Given this list of marker genes CNPY2-AS1, RNF13, CAPN15, FANCD2, ADHFE1, PDE6B, LINC01690, PARN, CCSAP, ENSG00000246308, BAIAP3, UTP15, DNAJC25-GNG10, JAKMIP2, ATP8B3, CIR1, OXSR1 (NCBI Gene Id 9943), EFNA3, TSPAN12, NDUFA11 (NADH:ubiquinone oxidoreductase subunit A11), CYP2J2, GTF2H4, MTND4P34, PARP1, MTG1, PEMT, DYRK1B, PLK3, IL6, ACADSB (acyl-CoA dehydrogenase short/branched chain), PFDN1, TMEM186 (NCBI Gene Id 25880), ABCG4 (ATP binding cassette subfamily G member 4), DLGAP5, SPECC1, ZNF160, ENDOG, ASNS, SUB1 (SUB1 regulator of transcription), STX18, DNAJC3-DT, APOO (apolipoprotein O), RAET1K, TRMO, GTPBP3, MIR367, ATP5MK, TRMT5, HTR5A, PTPRF, DYNLT2B, C9, AGPAT4, TREX1 (NCBI Gene Id 82474), HES4, ELOVL1, ZNF229, ZNF668, SOAT1, NT5DC3, ABCA7, CCDC159, ALKBH6, MTMR4, BAZ2B, SLC12A2-DT, ZNF292, CALM1, POLR3C, ATXN7, COPS7A, CXorf58, CDH23, RAB11FIP2, ZSCAN31 (NCBI Gene Id 91921), CIBAR1-DT, PTGES3, ZNF213-AS1, CLDN6, PLA2G4E-AS1, GPANK1, CNN3, SCRN3, MAP4K1-AS1, TBPL1 (TATA-box binding protein like 1), SNORD21, ARHGAP33, CFAP57, ZMYM4, SCGN, CCT6B, ENSG00000282849, SMG5, GPR89B, HECW2, MC1R, KCNT1, LINC01551, SLCO4A1-AS2, ATP5MC2, PDK4-AS1, CCDC192, PRR3, MYO3B-AS1, RNF166, WDR62, RARS1, MCTS1 (NCBI Gene Id 28985), NUP93-DT, ENO3, VPS13C, KIAA1217, DGKZ, CFDP1, LINC01778, BCL2L12, PHC3, RNF115 (NCBI Gene Id 27246), OGT, MEGF10, LMO4, TDRD7, FAM200A, NR4A1, LDLR, CREB3L2, ZNF500 (NCBI Gene Id 26048), CCDC8, RNF103-CHMP3, RNU4ATAC16P, CHMP6, SMARCC2, TNRC6C, LINC02614, ORAI2, AGPAT5, LINC01089, PPHLN1, MEPCE, CFL2, ZNF543, CD72, SCG3, LYRM1, DCTD, HNRNPD, KRBA1, YAP1, IFT140, ARAF, RNF103, PPP1R3B, ITGB3BP, NUP43, MMAB, CZIB-DT, RPA3, NHLRC3, MGST1, MIR760, NFKBIB, CDKN2A, H2AC25, B4GALT3, DLK2 (NCBI Gene Id 65989), CCDC169-SOHLH2, HEXA, RCAN1, TUBA1C, CEP131, FKBP14-AS1, ARID1A, RNF10, CAB39L, SDR39U1, CORO1A, MCCC1, ASCC1, VPS72, PSMA5, AOPEP, ANAPC11, ZNF429, REEP2, CAPN7, ALKBH3-AS1 (ALKBH3 antisense RNA 1), POLE3, CSNK2B, SLC12A2, OTULINL, LDB1, ODAD1, CLPB, FERMT2, C1QL3, OSBPL8, PPP2R5C, PHLPP2, RHOF, MAP2K5, POLA2, BAX, CAPS2, PIGQ, ATP5PD, GBA2, RPL15, RPS26, ZKSCAN2, RAB5B, RNASE11, RNU6-92P, TENT5C-DT, ARV1, KAZALD1, LETM2, ZFP64, DNAJC3, EBNA1BP2, PDGFRL, TM9SF4, KANK3, IKZF5, ZNF892, CASC2, ALYREF (Aly/REF export factor), SLC46A3, SEMA4B, SPNS2, CDR2, WDR59, LSMEM1, KLHL20, ITFG2, MAST4-AS1, TASOR2, BFSP1, SV2C, HIP1R, RWDD1, KIF22, RBPJ, MYLK-AS1, PCGF6, PSMD3, MAML1, RABEP2 (rabaptin, RAB GTPase binding effector protein 2), VARS2 (valyl-tRNA synthetase 2, mitochondrial), KCNK1, SOS1, ATP5MC3, CDR2-DT, CEBPB-AS1 (NCBI Gene Id 440766), RIF1, PDE8A, PEX13, RAB11A, LRRC49, KCTD7, BCAR3, PITPNM2, ACIN1, SCAF4, RNF139, LTBP3, CLIC1, THAP1, HOMER2, PROSER1, ZNF486, ENSG00000272008, ZEB1, SLC38A6, SREBF1, ZNF737, ZFHX2, CIDECP1, LMBR1L, PMEL, SNAP47, GLI2, SEC24B, OSBPL3, OXNAD1, SULT2B1, FOXN1, SPOP, PMVK, PYCR1-AS1, PYGM, NUP54, CCDC169, DSN1, CORO1A-AS1, CHKB-CPT1B, AP1G1, FBXW9, CCDC167, MCFD2, EDF1, CYP2S1, SLC25A15, ENC1, ENSG00000267698, LRRC37A5P, DCLRE1B, DPH3, LINC01607 (long intergenic non-protein coding RNA 1607), REEP6, HIF1A (NCBI Gene Id 3091), ERI2, DHRS13 (dehydrogenase/reductase 13), IGFL4, SLC36A1, ANAPC2, TCHP, ST6GALNAC6, C6orf118, MTND3P13, QNG1, H6PD, BRINP2, LIN54, OSR2, REPS1, UBE2O, PEAK1, ADCK2, RNU11, TBC1D16, TNC, GBA1, NTN3, SEPTIN9, MAP4K1 (mitogen-activated protein kinase kinase kinase kinase 1), C10orf95-AS1, EEF1AKMT3, ACTMAP, RASA4CP (NCBI Gene Id 402490), LPCAT4, DCDC2, ADAMTS13, CEP55, H2AZ1-DT, FBXL19-AS1, FLNA, RLF, ANKRA2, BCAP29, P4HA3-AS1, RNU7-179P, GPR137B, ATXN1-AS1, RIC8A, GDI2, SPAG1, ZNF655, APBB3, FYTTD1, LHFPL4, PMM2, GSAP, PCSK4, EBP, SNORA10, SLCO4A1, VMAC, SLC16A6, RALGDS, CEP89, DCUN1D3, ZFYVE16, ZFP1 (ZFP1 zinc finger protein), ZKSCAN8, FAM133GP, DNAJB9, UGGT2, NDUFA5, TARS2, NABP1, KIF20B, ZNF672, BAP1, CGA, CCDC57, ZNF438, METTL15, FAM199X, MTERF4, KMT2D, HTR3A, FOXK2, TNFSF13, UACA, GDI1, PRKCG, WDR55, DENND4A, RNF139-DT, STX18-AS1, PAK4, RFC1, SQSTM1, ITPRIP, RNU1-6P (RNA, U1 small nuclear 6, pseudogene), SEC61G, ITSN1, TJAP1, SNHG7, MAP3K12, GRK6, ISG15, SEC61A1, CASTOR3P, SLC35A4, MAD2L2, DSG1-AS1, SH2B3, MARCHF6-DT, GOSR2-DT, ZCCHC7, TARBP2, MACF1, RASD2, ACTN4, TMEM97P1, TAF1, CNN3-DT, GABPB2 (NCBI Gene Id 126626), DHRS4L1, PHF7, GFI1, JMJD4, RMI2, NTAN1, GNL1, SNRPA, ZNF689, EFL1P1 (NCBI Gene Id 727963), DNAJB12, ITPR1, GNG12-AS1, TMPRSS2, PHB1, ARHGAP24, NCEH1, TRIM44, LIMA1, CDC42SE1, PILRA, DDX12P, C4orf50 (chromosome 4 open reading frame 50), NID1, FBXO27, NUFIP2, SLC25A36, F11R, DST-AS1, HACD2 (3-hydroxyacyl-CoA dehydratase 2), CPEB4, TMEM170A, TMEM79, FAAP24, CMAS (NCBI Gene Id 55907), LINC01881, NMT1, EVL, PARP6, BTN3A3, LYPLA2, CCL3-AS1, RIBC1, MT1X, CSNK1A1, H2AC4 (H2A clustered histone 4), USPL1, MRPL48, RUSC1, SCAMP5, NEK2-DT, GFAP, ZNF385A, PSMB5, C1RL-AS1, SSBP1, TRIB1, ANKRD13C, TTF2, ATXN1, EFCAB14, METTL9, RFFL, RN7SKP276 (RN7SK pseudogene 276), CHCHD3, ABCA3 (NCBI Gene Id 21), EIF4G2, SLC25A51, PDCD2L, C5orf22, TM2D1, SPMIP8, STAT2, TUBG2, SKIDA1, ZNF362, STAP2, RPL27, GTPBP6, SYNJ2BP (synaptojanin 2 binding protein), MTF2, LRRC24, TLN1, HOXA9, MCM7, TCEA1, SDCBPP3, DHDDS, MICA (MHC class I polypeptide-related sequence A), MICU1, KDM4B, LINC00235, DYRK1A, STAT6, CENPE, SPSB4, TMEM218, LRRC8A, ZNF460, SEPTIN9-DT, MIR7850, ZNF540, DUSP14 (NCBI Gene Id 116242), HMGB1, IGFBP3, SRRM2, ARVCF, RUBCN, IFRD1, ANKRD13C-DT (NCBI Gene Id 11147), TSC22D4, EEF2K, CHD5, RPL18, RNA5SP433, GOSR2, ZNF217, SYNJ2BP-COX16, UBXN6, VARS1, ZNF85, CXXC5, COL6A4P1, KYAT1, EFEMP2, GTF2IP4, LINC01063, SPHK2, DZIP1L, WEE2-AS1, UBE2Q1, NCAPG2, LINC01569 (long intergenic non-protein coding RNA 1569), SELENOH, PDE12, MCPH1-AS1, GRHL3, GABARAPL1, FZD3, CRYZL1, MARCHF6, THAP5, CPNE7, MAX, YAF2, CRISPLD1, ARHGAP27, EFCAB2, GOLGB1, XIAP, MFN2, MPND, PRELID3BP5, PRPH, LINC03100, PXN, POP4, PIP4K2A, OTUB1, ANKRD50, PDZD2, CHKB-DT, SYDE1, SMC1A, DST, TADA1, SLC11A2, ALDOA, ITFG2-AS1, GOT1, FLII, TTC33, RUSC1-AS1, LINC02366, SLC25A23, GOT2, SLC30A10, NOP16, CZIB, ETV5, MRM2, THAP11, FLAD1, DSTN, TLCD2, RPS6KB1 (NCBI Gene Id 6796), TBX3, WDR26, LRRC10B, PADI2, GGT1 (gamma-glutamyltransferase 1), SYNRG, LASP1, MED26, ALDH1A2, GTF2IP12, FHAD1, ILF2, ACP6, EFCAB7, CDC14A (NCBI Gene Id 8556), IGDCC4, FBLL1, SEPTIN7P14, C5orf47, ARRDC3, COQ5, LSP1, ERCC3, COL9A3, LINC01010, ABCA17P, GPD1, EFCAB12, UTP6, ZNF131, PIK3CA, TUBD1, NUB1, GOT1-DT, WDFY1, JUP, TRIM2, NBPF19, DNAJC25, LTBP4, SEC61G-DT, CHKB, EVI5, OAS2, TBCB, TBCD (tubulin folding cofactor D), ACTB, RPL5, HINT2, SLC25A37, ZFP30, LNCTSI, HMG20A, WDR70, PNP (purine nucleoside phosphorylase), GMEB1, GPSM2, EPRS1, EPB41, NUDT18, PRSS16, SCN8A, COQ9, F12, TMEM101, LINC01803, CLDN3, PIAS1, CIAPIN1, RUNX1, ZNF460-AS1, MDH1, HIVEP3, ZNF330, ZMYM2, ELL, MIR194-1, DMD, PPIEL, WSCD1, AKAP8, AGBL3, CIBAR1, PRPSAP2, PLAU, CAT, ABCA5, PHF20, ISG20, RNU4-16P, RNF125, ZNF133, PPCDC, FSIP2LP, LINC01972, OXGR1, POLB, BRWD1, TLCD3B, B3GALNT2, FBXL19, CDKN2B-AS1, CD101-AS1, MCC, LRP10, FAM98C, ERGIC1, CACNA1A, ARRDC1, PNPLA8, KANSL1, ENSA, ZNF285, PUS10, PIEZO2, ANXA2R, TM4SF19-AS1, UBE2V1, IRF3, NDEL1 (NCBI Gene Id 81565), GARNL3, RNY1, KCTD2, RPP14, ASB6, RABGAP1L, HEXA-AS1, HOOK2, TTC13, TTLL6, MBLAC1, BBS1 (Bardet-Biedl syndrome 1), LINC02041, WDPCP, MIR302D, OSBPL7 (oxysterol binding protein like 7), IER5L-AS1, PRPF18, ROGDI, CCKBR, RIMKLB, SEC14L5 (SEC14 like lipid binding 5), TCTN1, ACAD9, UBE2I, MST1R, MAST4, HNRNPR (heterogeneous nuclear ribonucleoprotein R), CFAP65, MVK, SNAP91, LRP6, PTGES, RREB1, ISCA1, RPS6, PAMR1, DAB2, PURA, TVP23B, SIRT2, NHERF1, PLD6, ENSG00000261070, PDCD11, SEPTIN11, HOXC4, MACROD1, CS, RCAN3, HSD17B1-AS1, HMCN1 (NCBI Gene Id 83872), LINC00205, METTL1, SLC7A2 (NCBI Gene Id 6542), RAMAC, ATG9B, ARHGEF37, TUSC2, TLK1, ELSPBP1, HNRNPF, ENSG00000263080, MIR6853, TBC1D14 (TBC1 domain family member 14), COMMD3, IKBKB-DT, RDM1, MCF2L, SNORA14B, CHEK2, PITPNM1, IGLV6-57, GOLM1, EEF1A1, GNAI3, CEBPG, AKR1D1, PPP1R12A-AS2, ITGA9, MIR4488, RNF19A, DROSHA, LINC02453, ENSG00000269151, MAP3K15, PFN1, HTD2 (hydroxyacyl-thioester dehydratase type 2), NUP93 (nucleoporin 93), ZNF714, MTND4LP24, CREM (NCBI Gene Id 1390), LINC00957, UVRAG, ZMYM5, DACT1, THAP10, PDE7A, here is a description of the gene set: Human Gene Set: ZNF10_TARGET_GENES species: Homo sapiens Genes containing one or more binding sites for (ZNF10) in their promoter regions (TSS -1000,+100 bp) as identified by GTRD version 20.06 ChIP-seq harmonization. from publication Yevshin I, Sharipov R, Kolmykov S, Kondrakhin Y, Kolpakov F (PMID 30445619)